Given this list of marker genes MRPS25, MRPS16, MRPS27, MRPS6, MRPS10, MRPS21, MRPS18C, MRPS34, CHCHD1, MRPS31, MRPS2, MRPS26, MRPL42, MRPS18A, MRPS7, AURKAIP1, MRPS11, MRPS5, MRPS17, DAP3, MRPS33, MRPS24, MRPS28, PTCD3 (NCBI Gene Id 55037), MRPS22, MRPS14, MRPS9, MRPS23, MRPS35, MRPS12, MRPS15, MRPS18B (mitochondrial ribosomal protein S18B), here is a description of the gene set: Human Gene Set: GOCC_MITOCHONDRIAL_SMALL_RIBOSOMAL_SUBUNIT The smaller of the two subunits of a mitochondrial ribosome. studied in species Homo sapiens